Given this list of marker genes IGF2, ACTN3, NACA, DLL1, MTM1, here is a description of the gene set: Any process that activates, maintains or increases the rate of skeletal muscle growth. Human Gene Set: GOBP_POSITIVE_REGULATION_OF_SKELETAL_MUSCLE_TISSUE_GROWTH studied in species Homo sapiens